Given this list of marker genes Nr2f1, Mphosph9, Rtn4rl1, Itga2, Tesk1, Fscn1, Ccl21e, Kidins220, Rnd2, Akirin1, Cdk10, Ntm, Rtn4r, Lgals1, Prrx1 (paired related homeobox 1), Dpysl3, Lrrc7, Cntn1, Mboat1, Hdac6, Chrna3, Ryk, Tbr1, Cul7, Kif21a, Nf1, Ephb2, Ankrd1, Sarm1, Rab11fip3, Mapt, Syne2, Fyn, Nox1, Nefm, Ss18l1, Brsk1, Ret, Dynlt1c, Rapgef1, Sh3yl1, Mir124a-2, Ccl21d, Vim, Apc, Abl2, Cfl1, Nin, Braf, Anapc2, Inpp5f, Plxna3, Coro1b, Tmem106b, Daam2, Pak1, Spart, Draxin, Fuz, Kat2a, Trpv4, Snx3, Sipa1l1, Ift88, Syngap1, Mov10 (NCBI Gene Id 97060), Pak2, Itm2c, Ntrk3, Trim46, Adcy6, Mien1, Mapk15, Usp17le, Cdh1, Prkci, Wnt3a, Sema4d, Serpini1, Lzts1, Itgb1, Hrg, Fgfr1, Dnm2, Cxcl12, Ntrk1, Hdac4 (histone deacetylase 4), Arsb, Kalrn, Mtor, Fnbp1l, Mark2, Ranbp1 (RAN binding protein 1), Src, Septin9, Dennd5a, Mgarp, Fat3, Fxn, Zfyve27, Ins1, H2-K1, Tnr, Abl1, Adam17, Dpysl2, Ulk4, Ptprg, Zfp296, Adgrb3, Tsku, Cdh2, Cyth2, Ust, Brk1, Trem2, Washc5, Myo9a, Fstl4, Cav1, Prom2, Kif1a, Rufy3, Pld1 (phospholipase D1), Rac2, Arc, Arhgap4, Vil1, Bmp7, Slit1, Ccr5, Wrap73, Itpr1, Odad3, Klk6, Rab17, Ppfia2, Shoc2, Fam110c, Dbnl (NCBI Gene Id 13169), Pou4f2, Ppp1r16b, Avil, Ift140, Myo10, Eps8l3, Prkcq, Nlgn1, Atp8a2, Wnt7a, Pafah1b1, Auts2, Apoe, Anln, Def8, Abi3bp, Grin2b, Rgs2, Zmynd10, Sfrp2, Mir124a-3, Fig4, Slit2, Plce1, Ptprz1, Fgf13, Epha3, Map6, Stmn2, Trak1, Diaph2, Was, Efnb3, Tnik, Rab5a, Arpin, Mfn1, Fn1, Il6, Aqp1, Ezr, Gla, Ptn, Ctnna2, Arhgap33, Dab1, Il1rapl1, Flna, Tbx6, Apbb1, Zfp804a, Dpysl5, Grin1, Cdkl3, Limk2, Epha4, Setx, Tenm3, Ntng2, Nrdc, Rhoq, Stk25, Twf1, Tubb2b, Frmd7, Pdlim5, Sdc2, Ngef, Met, Ltk, Shank3, Numbl, Trpc5, Xlr3b, Atg5, Mark4, Arpc2, Tapt1, Pum2, Tacstd2 (tumor-associated calcium signal transducer 2), Syne1, Sirt1, Ripor2, Fez1, Magi2, Cd24a, Csmd3, Neurl1a, Bmp4, Tnn, Cux1, Enc1, Disc1, Snap25, Dynlt1b, Lrrc4c, Dleu2, Pak3, Ntrk2, Akap5, Bin3, Cdc20, Scn1b, Dync1i2, Lrp8, Tiam1, Pqbp1, Hgf, Grip1, Amigo3, Entr1, Ptpn1, Metrn, Fkbp4, Ccl21f, Kank1, Dynll1, Carmil2, Fbxw8, Kctd17, Plppr5, Mir132, Mak, Ccl21b, Lif, Neurog3, Ndel1, Crkl, Ndnf, Tnfrsf12a, Gprc5b, Tbc1d7, Wdpcp, Pten, Ccl19, Crmp1, Rhoa, Rp1, Lrp6, F2rl1, Gpm6a, Dvl2, Ep300, Tsc2, Stk24, Tgfb3, Lcn2 (lipocalin 2), Htt, Mfn2, B2m, Dab2ip, Bcl11a, Prag1, Cask, Styxl1, Atp8b1, Macf1, Kdm1a (lysine (K)-specific demethylase 1A), Adamts16, Plk5, Kif24, Obsl1, Atf1, Robo3, Map2k2, P2ry12, Ythdf1, Reln, Rab3ip, Tgfbr1, Hspb1, Hsp90aa1, Ywhah, Rab21, Pfn2, Itpka, Cdc42ep5, Glce, Htr7, Bmpr2 (NCBI Gene Id 98751), Abhd17b, Evl, Chn1, Icam1, Arhgap44, Igf1r, Mylip, Nedd4l (NCBI Gene Id 83814), Gak, Gdi1, Ift46, Cdc42ep2, Ahi1, Rcc2, Hnf4a, Nck1, Mcidas, Ptk2, Atp1b2, Efnb2, P2rx7, Trpc6, Gdi2, Nsmf, Nedd9, Sez6, P3h1, Tsc1, Pik3r1, Gsk3b, Kif26a, Cdh4, Acap3, Map3k13, Dynlt1a, Dync2li1, Eps8l1, Afdn, Adcyap1, Dlg4 (discs large MAGUK scaffold protein 4), Ddx56, Gpc2, Dnm1l, Camk1d, Sfrp1, Lpar1, Wasf2, Fzd4, Plek2, Clip1, Dkk1, Amigo1, Spock1, Dbn1, Eef2k, Rtn4rl2, Ptprd, Kit, Cpeb1, Klf4, Rabep2, Mstn, Kremen1, Megf8, Rap2a, Efemp1, Myo3a, Intu, Cln3, Rdx, Nfe2l2, Vps35, Myo3b, Ptpn9, Kif3c, Cobl, Nova2, Lyn (LYN proto-oncogene, Src family tyrosine kinase), Shox2, Elavl4, Pla2g3, Fbxo7, Sema6c, Limk1, Tbc1d30, Ush1c, Rapgef2, Mns1, Slc39a12, Noto, Cdc42ep3, Carm1 (NCBI Gene Id 59035), Cib1, Epo, Ppp1r35 (NCBI Gene Id 75603, protein phosphatase 1, regulatory subunit 35), Snap91 (NCBI Gene Id 20616), Ptk7, Numb, Fcgr2b, Camsap2, Mdm2, Pdpn, Lima1, Smurf1, Ccdc88a, Map2, Dvl1, Ppp2r5b, Ube2v2, Golga4, Wnt5a, Zmynd8, Atoh7, Gorasp1, Nme1, Adnp, Agrn, Podxl, Wdr44, Grid2, Bdnf, Clrn1, Marchf7, Lrp4, Cntrob, Eps8, Alk, D130043K22Rik, Cacna1a, Pou3f2, Arhgap35, Rnf6, Rit2, Ikbkb (NCBI Gene Id 16150), Nrxn1, Tiam2, Kif13b, Bmp5, App, Atmin, Rab29, Atg3, Chrnb2, Caprin1, Gfap, Camk2g, Prkcsh, Thoc2, Xk, Rab8b (NCBI Gene Id 235442), Prex1, Bag5, Nrcam, Ttbk2, Eif4g2, Fbxo38, Fes, Wnt1, Golga2, Cttn (NCBI Gene Id 68623), Ulk1, Carmil1, Nefl (neurofilament, light polypeptide), Cdc42ep4, Fmr1, Ccr7, Sema3f, Hecw2, Caprin2, Trpv2, Slc30a1, Epor, Neo1, Mdk, Stk11 (NCBI Gene Id 97678), Zdhhc15, Rab11a, Coro1c, Cdk5, Myo5b, Neu1, Actr2, Klf5, Dguok, Gap43, Ulk2, Il15ra, Lzts3, Nedd4, Yap1, Minar1, Wls, Marcks (myristoylated alanine rich protein kinase C substrate), Rreb1, Opa1, Pmp22, Ngf, Gm14137, Fkbp1b, Dcc, Inpp5j, Stau2, Skor2, Luzp1, Wnt3, Abi3, Nrp1, Actr3, Skil, Ifrd1, Ist1, S100a9, Ndrg4, Plxnb2, Tox, Map1b, Nrg1, Ap2a1, Eps8l2, Tenm1, Efhc2, Ncs1, Cit, Trim67, Espn, Rap1a, Hecw1, Srf, Islr2, Trak2, Negr1 (neuronal growth regulator 1), Ilk, Grn (granulin), Agt, Rtn4, Crk, Map2k1, Trpm2, Crocc, Cyfip1, Sema6d, Hdac2, Nptn, Bhlhb9, Stap1 (NCBI Gene Id 56792), Abitram, Bbs4, Arf6, Cdhr2, Lrrk2, Dixdc1, Hras (NCBI Gene Id 15461), Trim32, Dmtn, Iqgap1, Dock11, Parp6, Dgkg, Plxnb3, Creb3l2, Runx1t1, Rhog, Snapin (SNAP-associated protein), Hap1, Arap1, Sdccag8, Robo2, Dcx, Dvl3, Cxcl5, Mark1, Cd44, Eif2b2, Serpine2, Cspg4, Serpinf1, Cep120, Alkal1, Vldlr, Mag, Ddr1, Abi2, Dynlt1f, Efna1, Retreg3, Ins2, Prkd1, Rap1gap2, Ankrd27, Mfsd2a, Cdkl1, Cdc42ep1, Saxo1, Cimap3, Capzb, Nckap1, Stx1b, Xylt1, Itga3, Dynlt2b, Adam10, Dcdc2a, Id1, Twf2, Plxnc1, Acp4, Ntng1, Mbp, Cd38, Pcp4 (Purkinje cell protein 4), Ube3a, Zfp365, Sema7a, Odf2 (NCBI Gene Id 99090), Rgma, Cnr1, Nme2, Epha7, Ptprf, Pias2, Plxnd1, Neu4, Psen1 (NCBI Gene Id 19164), Ntn1, Mt3, Ptpn5, Dzip1, Sema3a, Qki, Scarb2 (NCBI Gene Id 320957), Nlgn3, Fam98a, Adcy10, Rapgef4, Mir212 (NCBI Gene Id 387208), Ift20, Dab2, Plxnb1 (NCBI Gene Id 70220), Fezf2, Plekhm1, Ezh2, Lpar3, Akt1 (thymoma viral proto-oncogene 1), Ptbp1, Cep135, Cflar, Kat2b, Sgk1, Paqr3, Pacsin1 (NCBI Gene Id 353072), Omg, Katnb1, Palm, Ermn (ermin, ERM-like protein), Tlx2, Wasl, Cdkl5, Hnrnpk, Cx3cl1, Cdhr5, Acsl6, Cntn2, Spry2, Ddr2, Mycbp2, Picalm, Fbxo31, Lrig2, Sema3g, Camk2b, Tbc1d24, Rrn3, Ppp3ca, Ppp1r9a, Ppp2r5d, Dnm3 (NCBI Gene Id 98663), Gfi1, Cenpj, Itga6, Srcin1, Crabp2, Crtc1, Dtnbp1, Arhgap32, Scarf1, Tmem67, Rala, Rap1gap (NCBI Gene Id 78775), Cbfa2t2, Dhx36, Cyld, Inppl1, Efna5, Dscam, Robo1, P2ry2, Adamts1, Thy1, Smn1, Ehd1, Ngfr, L1cam, Pls1, Alkal2, Crp, Rtn4ip1, Map4k4, Ccl21a, Brsk2, Sh3glb1, Ptk2b, Prl2c2, Pax6, Tenm2, Katna1, Nfatc4, Prkcd, Cdk5r1, Mir124a-1, Homer1, Tmem30a, Prnp, Tanc2, Fzd1, Ptprs, Lrp1, Evi5l, Nr2e1, Hes1, Zeb2, Ache, Cep97, Cux2 (NCBI Gene Id 73417), Rpl4, Rtca, Sphk1, Pfn1, Diaph1, Rac1, Cers2, Fut9, Arhgap24, Ccp110, Vegfa, Mir129-2, Khdc3, Gsk3a, Cntf, Fer, Tchp, Enpp2, Hspa5, Odf2l, Ephb3, Slitrk1, Shtn1, Arf4 (ADP-ribosylation factor 4), Sf3a2, Gata3, Atp7a, Ptk6, Kndc1, Ttc3, Sema4f, Dmd, Nckipsd, H2-D1, Camk1, Cdc42, Kel, Sema5a (NCBI Gene Id 320921), Chodl, Dip2b, Mob2, Epha2, Baiap2, here is a description of the gene set: Mouse Gene Set: GOBP_REGULATION_OF_CELL_PROJECTION_ORGANIZATION studied in species Mus musculus Any process that modulates the frequency, rate or extent of a process involved in the formation, arrangement of constituent parts, or disassembly of cell projections.